Given this list of marker genes Pgk1, Selenot, Txndc5, Dnajc10, Txndc2, Nxn, Glrx, Pdia4, Pdia6, Txn1, Gfer, Txn2, Pdia3, Clic3, Ero1a, Txnrd1, Tmx3, Txnrd3, Coa7, AU015836, Pdia2, Qsox2, Txnl1, Pdia5, Chchd4, Txndc12, Qsox1, Ero1b, Glrx2, Txnrd2, P4hb, Tmx1, Sco2, Txndc17, here is a description of the gene set: Catalysis of the reaction: a protein with reduced sulfide groups = a protein with oxidized disulfide bonds. species: Mus musculus Mouse Gene Set: GOMF_PROTEIN_DISULFIDE_REDUCTASE_ACTIVITY